The following is a description of a gene set: Human Gene Set: AP1_Q4_01 Genes having at least one occurrence of the motif TGAGTCAN in the regions spanning 4 kb centered on their transcription starting sites. This matches the JUN transcription factor binding site V$AP1_Q4_01 (v7.4 TRANSFAC). species: Homo sapiens, and this is the list of marker genes: TLL1, SKIDA1, KRT8, GJA1, KRT25, MAP2 (NCBI Gene Id 4133), HBEGF, NR0B2, TUBB4A, CCDC120, FBXW11, SRPK2, SYTL1, SV2B, FAM184A, SRSF2, C19orf33, ABCF3, EPB41L1, COL16A1, PAPPA, PSTPIP1, EMP1, WNT7B, SLC16A6, ABHD4, PCDH17, CA7, SLC4A11, FSTL1, PCYT2, LRRC8E, BAZ2A, MPV17, WDFY3-AS2, MNT, HOXA11, AP2M1, IL11, IGSF9, LNX1, TNXB, GRIA1, AQP5, BACH1, SYT2, ITGB4, PSME4, ADCY8 (adenylate cyclase 8), GSE1, MAP4, PKP3, PSMD1, MYH14, SYNGR1, BNIP3, DUSP14, LMOD3, PSMD11, RBP4, BBLN, ZNF436, LORICRIN, CAMKK1, CKMT1B, FBXO44, MSI1 (musashi RNA binding protein 1), HCLS1, NDRG2, GAPDH, CSF3, BCL9L, FOSL1, OLR1, SPATA16, ECM1, ATP1B1, AK5, SPATS2, LAMC2, H3-3B, PLBD2, TTC1, AKT3, RAB3D, ZNF827, PRR7, LYSMD2, NDP, MYBPH, SCAMP1, CHST1, SH3RF2, BAG2, ENO1, RNF144B, MARK1 (NCBI Gene Id 55887), TENT5B, TAF15, MIDEAS, BLMH, PROSER3, SEPTIN9, CHST4, SYNPO, RELA, GNAI1, SQSTM1, MAMDC2, CRYGS, RGS2, RIN1, ANKRD28, SLC26A9 (NCBI Gene Id 65013), MYB, RHBDF1, TOB1, ESRRG, SLC24A4, CYTOR, PADI4 (NCBI Gene Id 82795), PSMD4, MAPRE3, EPHB2, CSMD3, CD68, ANXA7, C15orf39, HSPB8, MYOZ2, LINC02694, ZNF385B, FGF11, PPP2CA, PEA15, UCN2, EML3, HSPB6, HS3ST2 (NCBI Gene Id 9956), SLC35B1, CLIC1, UBALD1 (NCBI Gene Id 124402), RPS6KA4, CNTF, GKN1, RB1CC1, RBPJ, DTNA, ABCD1, VIT, EPHX4, NRAS, FAM81A, TENT5A, FGF12, TINAGL1, CRYBA2, IQSEC1, ZPBP2, SEC24D, NR1D1, HCN3, CDH23, SHC3, NTN4, SFN, DDIT3, PHLDA2, UBE2E3, VDR, KCNA2, ROM1, FABP4, NCDN, BTK, TIAL1, REXO2, PHLDB3, PRDM1, GDNF, PLCD1, SLC26A1, RIT1, PRX, PPP1R15A, XIRP1, RTN3, LTBP3, CDKN1A, ZFAND5, KCNH6, ITPKC, CSF1R, RNF34, PPP1R9B, MCTP1, ALDOA, DHRS3, PTPRN, MARK4, PVALB, TFE3, LAMC1, VAPA, RBBP7, LYVE1, ETV5, SNCB, DYNC1H1, SSH2, C2CD2L, ELK3, IL10, GADD45A, RBM39, FRMD5 (NCBI Gene Id 84978), TRAF3 (TNF receptor associated factor 3), TMCC1, CYRIA, CMAS, ADAM15, NEFH, MAP4K5, PLEKHH3, GTF2B, COBL, ELAVL2, EN1, GTPBP2, TYSND1, RTL9, SNX10, ITM2B, CALB2, OMG, COQ8B (coenzyme Q8B), WDFY3, XPOT, USP3, HDAC3, TSR1, P2RX6, TMEM151A, FBRS, USP2, SRPX2, DYRK1A, LAMA3, TREX1, CXCR5, VASP, WNT6, MMP9, BICDL1, LRRTM3, S1PR1, DIRAS1, C1orf21, FBXO2, SLC38A3, COL7A1, YIF1A, RELL2, RIMS1